The following is a description of a gene set: studied in species Mus musculus Orexin and neuropeptides FF and QRFP bind to their respective receptors Mouse Gene Set: REACTOME_OREXIN_AND_NEUROPEPTIDES_FF_AND_QRFP_BIND_TO_THEIR_RESPECTIVE_RECEPTORS, and this is the list of marker genes: Qrfp, Npff, Qrfprl, Npffr2, Hcrt, Hcrtr1, Hcrtr2, Npffr1